The following is a description of a gene set: Mouse Gene Set: GOBP_DIOL_BIOSYNTHETIC_PROCESS The chemical reactions and pathways resulting in the formation of a diol, any alcohol containing two hydroxyl groups attached to saturated carbon atoms. studied in species Mus musculus, and this is the list of marker genes: Sptssa, Acer1, Dhfr, Qdpr, Agk, Sphk2, Gch1, Acer2, Asah2, Sptlc1, Pcbd2, Acer3, Ephx1, Pcbd1, Sptlc3, Asah1 (NCBI Gene Id 67617), Gba1, Pts, Spr, Sptlc2, Abca2 (NCBI Gene Id 98943), Sptssb (NCBI Gene Id 66183), Sphk1